The following is a description of a gene set: Human Gene Set: GOBP_ALKALOID_METABOLIC_PROCESS The chemical reactions and pathways involving alkaloids, nitrogen containing natural products which are not otherwise classified as peptides, nonprotein amino acids, amines, cyanogenic glycosides, glucosinolates, cofactors, phytohormones or primary metabolites (such as purine or pyrimidine bases). studied in species Homo sapiens, and this is the list of marker genes: CYP3A5, CYP1A2, CYP3A4, CYP2D6, NNMT, BCHE